Given this list of marker genes TARM1, ADAM15, FES, CLEC4D, IGHG4, CR2, ADAM8, FGR, IGHE, ADAM28, JCHAIN, IGHG1, IGHG3, IGHG2, IGHD, IGHA2, IGHA1, FLNA, IGHM, here is a description of the gene set: Binding to one or more specific sites on an immunoglobulin receptor molecule. species: Homo sapiens Human Gene Set: GOMF_IMMUNOGLOBULIN_RECEPTOR_BINDING